Given this list of marker genes VAMP4 (NCBI Gene Id 8674), EEA1, PIK3C3, VAC14, RAB11A, SNX4, RAB7A, VTI1B, AP3D1, RABGEF1, here is a description of the gene set: Human Gene Set: GOCC_PRESYNAPTIC_ENDOSOME studied in species Homo sapiens An endosome present in the presynapse that fuses with endocytic vesicles arising in the presynaptic endocytic zone. This organelle is believed to be involved in regeneration of synaptic vesicles.